Given this list of marker genes Hc, Fpr-rs7, Oxsr1, Gata3, Pdgfb, Mmp9, Gas6, Trpv4, BC037156, Stk39, Nedd9, Cd69, Myo1g, Itgal, Itga4, C5ar1, Selenok, Ptpro, Il12a, Ccl3 (NCBI Gene Id 20302), Pycard, Gpr15, Cd200, Ccr1, Ccl19, Lrp12 (NCBI Gene Id 239393), Ripk3, Cd47, Aif1, Ch25h, Coro1a, Ager, Cxcl17 (NCBI Gene Id 232983), Kcnn4, Ccl21a, Ccr1l1, F11r (NCBI Gene Id 226655), Cd200r1, Mst1, Tbx21, Adam8, Thbs1, Mtus1, Ptprj, Slamf8 (SLAM family member 8), Ccl19-ps1, Tafa4, Ano6, Tnfsf4, Gcsam, Hsd3b7, Tnfsf14, Gpr15lg, Msmp, Wnt5a, P2ry12, Ecm1, Enpp1, Ror2, Arhgef5, S100a14, Ctsg, Ccl5, Slamf9, Ccl21d, Tnfrsf14, Stap1, Crtam, Anxa1, Trem1, Asb2, Ednrb, Mapk3, H2bc1, Adam17 (a disintegrin and metallopeptidase domain 17), Lrch1, Padi2, Nlrp12 (NLR family, pyrin domain containing 12), Adam10, Cxcr3, Ccr6, Klrk1, Fadd, Akt1, Ccl19-ps6, Madcam1, Mstn, Wnk1, Ascl2, Ccl7, Tnfsf18 (tumor necrosis factor (ligand) superfamily, member 18), Lyn, Mmp28, Ccl19-ps4, Fut7, Plec, Trim55, Ccl26, Fpr2, Rarres2, Itgb3, Calr, Mmp14, Cnn2, Dusp1, Artn, Rpl13a, Abcc1, Cklf, Il34, Ifnb1, Cxcl11, Gpr183, Ripor2, Ccr2, Ccn3, Cmklr1, Ccl12, Gba1 (glucosylceramidase beta 1), Jam3, Grem1, Lgals3, Spns2, Spi1, Hmgb1, Adtrp, Ccl20 (NCBI Gene Id 20297), Cd9, Jam2, Jaml, Icam1, Slit2, Ccl1, Rps19, Mcoln2, Cxcl16, Tnfsf11, Trpm4, Edn2, Mapk1, Aire, Mmp2, Fpr-rs4, Ccl21e, Pdgfd, Med23, Akirin1, Sirpa, Alox5, Ptk2, Spn, Creb3, Msn, Abr, Lgals9, Slc8b1, Il4, Ccr7, Abl2, Cxcl14, Serpine1, Ggt5, Cd81, Flt1, Rtn4, Cx3cr1, Myo9b, Cyp7b1, Plg, Cd99l2, Defb25, Fpr-rs3, Bcr, Fut4, Trpm2, C3ar1, Nbl1, Dock8, P4hb, S1pr1, Ccl21b, Pla2g7, P2rx4, Slc12a2, Eps8, Ccl19-ps3, Itgb7, Crk, Slamf1, Stk10, Il27ra, Gpr35, Pecam1, Ptk2b, Crkl, Mospd2, Csf1, Rhoa, Cdc42, Ninj1, C1qbp, Mia3, Nup85, Tmem102, Tgfb1, Ccl2, Plcb1, Ext1, Fpr-rs6, Trem2, Cxcl10, Abl1, Csf1r, Gnai1, App, Retnlg, Apod, Mdk, Lgmn, Xcl1, Wasl, B4galt1, Cyp19a1, Ccl21f, Cxcl13, Mif, Emilin1, Cadm1, Cxcl12, Cx3cl1, Ccl19-ps5, here is a description of the gene set: studied in species Mus musculus The movement of a mononuclear cell within or between different tissues and organs of the body. Mouse Gene Set: GOBP_MONONUCLEAR_CELL_MIGRATION